Given this list of marker genes ACACB, MFSD2A, AKT1, PLIN5, ETFBKMT (electron transfer flavoprotein subunit beta lysine methyltransferase), here is a description of the gene set: Human Gene Set: GOBP_NEGATIVE_REGULATION_OF_FATTY_ACID_BETA_OXIDATION species: Homo sapiens Any process that stops, prevents, or reduces the frequency, rate or extent of fatty acid beta-oxidation.